Given this list of marker genes Scx, Acvr1b, Cygb, Mfap4, F2, Ccn2, Creb3l1, Serpinf2 (serine (or cysteine) peptidase inhibitor, clade F, member 2), Wnt4, Vim, Idua, Ep300 (E1A binding protein p300), Ppard, Nr1h4, Mkx, Ihh, Tgfb3, Pdgfrb, Fgfr3, F2r, Ucn, Ltbp1, Itgb1, Serpine1, Ddr2, Pdgfb, Cbx8, Bmp4, Rap1a, Notch1, Myb, Rapgef3, Pparg, Vsir, Tgfb1, Emilin1, Dicer1, Larp6, Prdx5, Il6ra, Got1, Adora2b, Nppc, Ager, Eng, Retn, Ccl2, Il18, Cst3, Inhba, Itga2, Fap, Errfi1, Rgcc, Cyp7a1, Cyp2j6, Gli2 (GLI-Kruppel family member GLI2), Serpinb7, Arrb2, Uts2, Suco, Il6, Fn1, here is a description of the gene set: Any process that modulates the frequency, rate or extent of the chemical reactions and pathways resulting in the metabolism of collagen, any of a group of fibrous proteins of very high tensile strength that form the main component of connective tissue in animals. studied in species Mus musculus Mouse Gene Set: GOBP_REGULATION_OF_COLLAGEN_METABOLIC_PROCESS